Given this list of marker genes APPBP2, FES, ABTB2, PMP22, CEP57 (centrosomal protein 57), TMEM161B, ID2, HPD, CBLB, NPHP4, DAGLA, ATP6V0A4, AMPH, LINC01565, GNB1L, FAM76B, NCKIPSD, DSTN, LGI3, SLITRK1, SMOX, HMGN5, STIM1, PRG4, ZNF654, PRMT6, SDCBP2, NOTCH4, CCDC6, SNX1, KCNH2, RELCH, PIM2, PER2, ITPKB, FAM162A, VGF, C6orf62, TXNIP, HOXC12, CIART, BRINP1, NDC1, LUC7L3, PER1 (period circadian regulator 1), MPLKIP, CFAP65 (cilia and flagella associated protein 65), PPP3CB, DAB2IP, SCNN1A, LUC7L, LRRC8A, NAT14, USP54, USP2, SPEG, SUGCT (succinyl-CoA:glutarate-CoA transferase), TMED9, KCNA5, IGSF21, STX19, LARP4, TRIM63, STOML2, CALCRL, CLDN10, ELL2, ECI1, ANGPTL2, GOT2, FAM107A, RBM24, PSME2, LINC00670, ADAM7, TRIM54, TMEM52, ETV5, SIPA1, AGRP, KIF13A, SIX1, S1PR1, CD36, SLC25A45, KLF15, PCDH1, TNRC6A, LINC00114, WNT7A, C1orf43, CDKN1A, ZMYND8, TGIF1, R3HDM2, PITX3, IL16, XK, ZNF532, PRDM1 (NCBI Gene Id 639), SOX10, PHF21A, SLC9A5, DTNB, RBM15B, TP53BP1, SLC38A3, C6orf136, IP6K3, KRT222, RAB10, RTKN, SLC7A8, SNAP25, FXYD1, TRERF1, SYMPK, FOXJ3, ZNF800, SPTBN1, OLFM1, IKZF2, ZNF513, BCL6, FOXA3, PANK1 (NCBI Gene Id 53354), JAK2, BARHL2, TSC22D3, NCDN, FILIP1 (filamin A interacting protein 1), LIFR, NAT8L, EVA1C, TRIM50 (NCBI Gene Id 260316), RBMS2, ITGA7, SLC29A2, UBE2Z, MXD4, SF3B1, PA2G4, RTL3, PDXK, NDST2, ADNP, SREK1, SGK1, RTL10, SLC43A1, HNRNPD, IP6K2, STX12, PSMA6, MT2A, CSAD, CYRIA, LINC00472, here is a description of the gene set: Human Gene Set: AR_01 species: Homo sapiens Genes having at least one occurrence of the motif GGTACANNRTGTTCT in the regions spanning 4 kb centered on their transcription starting sites. This matches the AR transcription factor binding site V$AR_01 (v7.4 TRANSFAC).